The following is a description of a gene set: Human Gene Set: GOMF_AMINO_ACID_TRANSMEMBRANE_TRANSPORTER_ACTIVITY studied in species Homo sapiens Enables the transfer of amino acids from one side of a membrane to the other. Amino acids are organic molecules that contain an amino group and a carboxyl group., and this is the list of marker genes: SLC38A4, SLC6A5, SERINC3, SLC1A1, SLC7A2, SLC7A11, SLC25A13, SLC38A3, SLC1A2, GRIN3B, SLC38A1, SLC6A14, SLC6A11, SLC43A1, GRIK3, SLC17A6, SLC25A22, GRIN2D, SLC7A10, SLC7A5, GRID2, SLC36A3, GRIA3, SERINC5, SLC16A10, GRIN1, SLC6A13, SLC25A15, SLC1A3, SLC3A1, SLC7A13, SLC6A20 (solute carrier family 6 member 20), SLC38A5, SLC38A7 (solute carrier family 38 member 7), PDPN, SLC36A4, SLC38A2, GRIN2B, SLC1A4, SLC36A1, SLC16A2, MFSD12, SLC66A1, SLC38A11, GRIK4, SLC22A2, GRIK5, SLC6A12 (solute carrier family 6 member 12), TSPO2, SLC25A26, SLC25A12, NHERF1, CTNS, SLC38A9, SLC38A8 (solute carrier family 38 member 8), SLC15A4, SLC1A5, SFXN1, SLC32A1, SLC38A6, SLC25A29, SLC7A3, GRID1, SLC43A2, GRIA4, GRIA2, SLC47A1, SLC25A38, SLC7A1, SLC17A7, SLC6A9, UCP2, GRIA1, GRIN3A, GRIK2, GRIK1 (NCBI Gene Id 2897), SLC1A7, SLC22A4, SLC7A14 (NCBI Gene Id 57709), SLC6A8, SLC6A15, SLC7A9, SLC25A2, SLC38A10, SLC6A7, SFXN3, SLC17A8 (solute carrier family 17 member 8), SLC7A7, SLC1A6, SLC6A19, TMEM44, SLC7A8, GRIN2A, SLC7A6, SLC6A18, SLC6A1, SLC66A1LP (NCBI Gene Id 652000), GRIN2C, SLC36A2, SLC3A2, SLC25A18, SLC6A6, SLC7A4 (solute carrier family 7 member 4)